Given this list of marker genes Edn1, Adrb1, Ep300, Tbx1, Atp11a, Bcl2, Shox2, Efnb2 (NCBI Gene Id 13642), Myf5, Fdps, Mylk3, Myf6, Mapk14, Wnt3a, Shh, Mmp14, Smyd1, Nrg1, Trim32, Bmp4 (bone morphogenetic protein 4), Actn3, Igf1, Prkd1, Neu2, Ccn4, Ddx39b, Parp2, Piezo1, Slc25a4 (NCBI Gene Id 11739), Maml1, Trip10, Mesp1, Myod1, Tgfb1, Myog, Csrp3, Nek5, Nr3c1, Cyp26b1 (NCBI Gene Id 232174), Gsk3b, Morf4l2, Kat2a, Rbm24, Arrb2, Pin1, Prox1, Akap6, Mtor, Hamp, Epc1, Hamp2, Bmp10, Sirt1, Mef2c, Lmod3, Cav3 (caveolin 3), Myocd, Hopx, Pin1rt1, Mamstr, here is a description of the gene set: Any process that activates or increases the frequency, rate or extent of striated muscle cell differentiation. Mouse Gene Set: GOBP_POSITIVE_REGULATION_OF_STRIATED_MUSCLE_CELL_DIFFERENTIATION studied in species Mus musculus